The following is a description of a gene set: species: Homo sapiens An adaptor activity that brings together a protein and a region of the chromatin, such as a nucleosome, to establish or maintain the chromatin localization of the protein, or the complex to which it belongs. Human Gene Set: GOMF_CHROMATIN_PROTEIN_ADAPTOR_ACTIVITY, and this is the list of marker genes: MORC3, DPF2, RRP8, TAF7 (TATA-box binding protein associated factor 7), ZMYND8, STK38, ING4, SUZ12, FMR1, MSL3, L3MBTL2, HDGFL2, RAD17, MORC4, UVSSA, CBX5, L3MBTL1, BRD4, GLYR1, DPPA3, EPC1, XIST, BRD3, NCAPD3, ING1, CHD1L, UHRF1, NCAPG2, TTLL12, UHRF2, SPIN3, PHF14, ERCC6, PIH1D1, PYGO1, CBX8, CASC11, ZCWPW1 (zinc finger CW-type and PWWP domain containing 1), SGF29, BRD7, RPA1, RNF169, WDR5, PARTICL, THAP7, H2AX, CCDC38, DNAJC2, ATRX, BARD1, ZMYND11, PWWP2A, TAF3, BRDT, SPIN2B, FIRRE, TDRD3, CDY1 (chromodomain Y-linked 1), MEG3, PHF1, CHD8, BRD1, TP53BP1, FGF2, NBN (NCBI Gene Id 4683), TONSL, CXXC1, MTF2, MPHOSPH8, BRCA1, PHF2, MALAT1, MBTD1, PHF8, SPIN2A, ING2, LRWD1, BRD2, ING3, NEAT1, CHD1, LBR, BAZ2A, MECP2, PHF13, MLLT3, YEATS4, RHNO1, TAF1, CHD5, JARID2, MSH6, HTATSF1, YEATS2, KDM4A (NCBI Gene Id 9682), KMT2E (lysine methyltransferase 2E (inactive)), ZCWPW2, CDYL2, UIMC1, TOPBP1, ZNF618, ING5, SPIN4, CBX2, H1-2, MDC1, SPIN1, PTENP1-AS, RAG2, CDY1B, PHF19, USP15, PWP1